Given this list of marker genes THRB, PDE6B (NCBI Gene Id 5158), AKT2 (AKT serine/threonine kinase 2), GDF6, MIR21, DIO3, CLN8, here is a description of the gene set: Any apoptotic process in a retinal cell. Human Gene Set: GOBP_RETINAL_CELL_APOPTOTIC_PROCESS studied in species Homo sapiens